The following is a description of a gene set: Genes predicted to be targets of miRBase v22 microRNA hsa-miR-1302 in miRDB v6.0 with MirTarget v4 prediction scores > 80 (high confidence targets). studied in species Homo sapiens from publication Chen Y, Wang X (PMID 31504780) Human Gene Set: MIR1302, and this is the list of marker genes: HUWE1, SYT10, ESR1, TM6SF1, SHPRH, PTK2B, GCSAM, CEP20, CDK19, LIAS, NEXMIF (NCBI Gene Id 340533), ZNF736, STMN1, DISC1, ZRANB1, TIPRL, ARID5B, PLAAT2, CTBP2, CSGALNACT2, FBXO11, RAB23, ARHGAP32, SCN4B, RNF4, COL4A3, PPM1F, PER1, ENSG00000255537, CELF1, UMPS, ENSA (NCBI Gene Id 51620), OST4, SPIDR, ING2, PSMC4, LIX1L, RABGAP1L, YWHAZ, NMBR, GMEB1, BTF3L4, DOCK3, ONECUT2, NEDD1, SMAD2, FNBP1L, KCNB1, ITGAE, RUSC1, ATL2, TRARG1, NRF1, MDN1, SLC36A4, SKP1, MINDY3, PECR, ALDH5A1, FKBP7, TASOR, MAP2K3, TRPS1, CAVIN3, OBSL1, UBA6, VSNL1, BCO2, SEPTIN3, C11orf58, LHX6, NAA30, PGM1, RASL10B